Given this list of marker genes Erc1, Pclo, Bsn, Rims1, Ctbp2 (C-terminal binding protein 2), Rims2, Rimbp2, Erc2, Rab3a, here is a description of the gene set: A process which maintains the organization and the arrangement of proteins at the active zone to ensure the fusion and docking of vesicles and the release of neurotransmitters. studied in species Mus musculus Mouse Gene Set: GOBP_MAINTENANCE_OF_PRESYNAPTIC_ACTIVE_ZONE_STRUCTURE